The following is a description of a gene set: Genes down-regulated in E14 ES (embryonic stem) cells upon knockdown of CYCT2 by RNAi. The positive transcription elongation factor b (P-TEFb) is essential for the elongation of transcription and cotranscriptional processing by RNA polymerase II. In mammals, it contains predominantly the C-type cyclin cyclin T1 (CycT1) or CycT2 and cyclin-dependent kinase 9 (Cdk9). To determine if these cyclins have redundant functions or affect distinct sets of genes, we genetically inactivated the CycT2 gene (Ccnt2) using the beta-galactosidase-neomycin gene (beta-geo) gene trap technology in the mouse. Visualizing beta-galactosidase during mouse embryogenesis revealed that CycT2 is expressed abundantly during embryogenesis and throughout the organism in the adult. This finding was reflected in the expression of CycT2 in all adult tissues and organs. However, despite numerous matings of heterozygous mice, we observed no CycT2(-/-) embryos, pups, or adult mice. This early lethality could have resulted from decreased expression of critical genes, which were revealed by short interfering RNAs against CycT2 in embryonic stem cells. Thus, CycT1 and CycT2 are not redundant, and these different P-TEFb complexes regulate subsets of distinct genes that are important for embryonic development. from publication Kohoutek J, Li Q, Blazek D, Luo Z, Jiang H, Peterlin BM (PMID 19364821) Human Gene Set: KOHOUTEK_CCNT2_TARGETS studied in species Mus musculus, and this is the list of marker genes: CPSF4L, ZC3H13, EPDR1, TRIM67, CCNT2, LEFTY2, MYO1F, HOMER2, NOTCH4, RETSAT, CDX2, RBP7, TRH, GNAI1, SALL3, CROCC2, NODAL, TET1, FLYWCH2, CEP97, MMP2, CCNO (cyclin O), PSORS1C2, SP5, NT5E, DPP4, CENPM, DDX6, SNX30, MAN2B1, TMEM253, MLXIPL, CALCA, PRAMEF12, DCXR, ST3GAL6, C1orf198, GSTT2, LMNTD2, HAS2, SLC4A7, GABARAPL1, FST, CRLF1, FZD10, CERCAM, TRMT1, RNASEH2C, NEXMIF, CSN3, TMEM54, TEX19, NANOS3, CEP295, CFAP144, NPHS1, LEFTY1, ARL4A